Given this list of marker genes Cntn2, Drd1, Arl13b, Lhx6 (LIM homeobox protein 6), Arx, Nrg1, Rac1, Fezf2, Nrg3, Drd2, here is a description of the gene set: species: Mus musculus Mouse Gene Set: GOBP_SUBSTRATE_INDEPENDENT_TELENCEPHALIC_TANGENTIAL_MIGRATION The process where neuronal precursors migrate tangentially in the telencephalon, primarily guided by interactions that do not require cell-cell contact.